Given this list of marker genes CD3E, MR1, EPS8L1, STOML2, FYN, HLA-E, LCK, CD3G, HLA-A, HLA-DRB1, HLA-DRA, DOCK2, here is a description of the gene set: studied in species Homo sapiens Human Gene Set: GOMF_T_CELL_RECEPTOR_BINDING Binding to a T cell receptor, the antigen-recognizing receptor on the surface of T cells.